Given this list of marker genes SMOC1, ALG2, FBXL3, TBR1, RUSC2, SOX4, IFT43, USP9X, COL1A2, KMT2A (NCBI Gene Id 79951), FAT4, ZMIZ1, PORCN, ZMYM2, GZF1, CTCF, B3GAT3, B4GALT7, ARFGEF2, SERPINF1, PKDCC, FERRY3, CHAT, FBXO11, MAP1B, SET (NCBI Gene Id 6418), TMCO1, MLXIPL, SHANK3, LRP5, PYCR2, PLK4, KDM3B, DLK1, POLR1A, CREBBP, EFNB1, ZNF341, TRIM8, SLC26A2, SEC24D, COL6A1, POGZ, DSE, EXOC6B, BBS1, WDPCP, BBS12, CHST14, TUBB3, MKKS, NSMF, ROR2, DNA2, LTBP4, STX1A, RAB3GAP2, CENPE, SLC39A13, SCAPER, GFPT1, HOXD13, KCNJ2, EP300, ALG14, ZFX, FOCAD, NPR3, ARL6, TAF1, MCTP2, GPC4, USB1, STAT4, ORC4, FMR1, IL1RAPL1, WASF1, TRAIP (NCBI Gene Id 10293), PAX2, COL6A3, RNF125, ABCC6, TBX1, SPARC, TTC8, SON, ATP6V1E1, KDM1A, FBLN5, PMM2, TGDS, TCTN3, ATRIP, STAC3, HNF1B, GJA8, KCNJ5, JMJD1C, SLC6A9, SIN3B, MAPK1, TACR3, COMT, PUS1, IL6ST, COL18A1, ARCN1, ORC6, B3GLCT (NCBI Gene Id 145173), NOTCH2, IL2RA, ADGRL1, ATN1, SLC10A7, SOS2, OTUD6B, RTL1, DPYSL5, FGF8, SLC25A1, JARID2, RASA2, SPART, CANT1, GMNN (NCBI Gene Id 51053), TNFRSF1A, RRAS, TBL2, FKBP6, SMAD2, SEMA5A, NPHP1, PROKR2, UFD1, PUF60, CSNK2A1, KMT2D, ELN, COL13A1, RAI1, HEPHL1, ANTXR1, YY1, HYMAI, LZTR1, DPF2, PPP1CB, CDT1, LONP1, RIN2, STAG1, SCARF2, PCNT, SIN3A, BBS7, ARVCF, UBE3A, SHOC2, UPF3B (NCBI Gene Id 65109), RECQL, DCPS, FGFR1, RAB3GAP1, KDELR2, LMNA, MBTPS2, SOBP, STRADA, EN1, RRAS2, NRAS, NEDD4L (NCBI Gene Id 93998), TRPS1, ECEL1, NUP85, MED12, ADAMTSL2, BAZ1B, PIGU, STAT3 (NCBI Gene Id 6774), PRDM5 (PR/SET domain 5), CRTAP, RIT1, HS6ST1, SPTAN1, CHAMP1, GP1BB, SNAP25, DDRGK1, PGM2L1, IFT122, GDF5, CCNQ, GLB1, SMARCE1 (SWI/SNF related, matrix associated, actin dependent regulator of chromatin, subfamily e, member 1), HNRNPK, PPP2R1A, SLC6A8, P4HTM, AP4S1, NSD1, COLEC11, SMARCA2, SYT1, ATP6AP1, MAP3K20, TAOK1, CRKL, GNE, RFX7, TRIM32, SPTBN1, ATP7B, KCNN3, CREB3L1, SMARCB1, TCF12, CCDC8, PAK2, SNUPN, ATP6V1B2, RMRP, NFIX, MRE11, NSUN2, BBS2, PIGT, TBL1XR1, DLG4, IFT74, MEG3, HNRNPH2, COL9A1, PIGP, AP1G1, TRIP11, NCF1, VPS13B, METTL27, TAC3, FKBP10, SLC35A2, LZTFL1, CDK10, GNB1, BBS4 (Bardet-Biedl syndrome 4), MKS1, ESAM, CHST3, H3-3B, COL9A3, DCHS1, PHF6, BBS10, NKAP, MTM1, EXT1, TMEM270, ARID1A, FGF17, RPS6KA3, ASPH, LMX1B, SLC35B2, SMS (spermine synthase), KDM6B, SDCCAG8, AP4M1, CTNND2, PLOD1, PYROXD1, SLC18A3, MICU1, GORAB, XYLT2, AEBP1, PTHLH, GATAD2B, YWHAG, MAN2B1, WNT1, KDM6A, OCRL, CD247, HYAL1, EIF4H, ZDHHC9, AGA, DNMT3A, ATP6V1A, IFT52, SCAF4, MARS1, BGN, DUSP6, BMP1, NANS, COL2A1, CUL4B, PHIP, SRCAP, SMARCA4, IPO8, TONSL, TELO2, MAP3K7, HNRNPH1, FARSB, KISS1, PLAGL1, TOGARAM1, CHD7, PCGF2 (polycomb group ring finger 2), MRAS, SATB1, RREB1, DHX30, RNF13, PPP1R15B, SPRED2, TGFB2, COL1A1, TANC2, CEP19, COL3A1, NEPRO, RYR1, HRAS, AP4E1, SYT2, MEFV, TMEM165, GAN, KAT6B, GNRHR, LIG4, IARS2, ARID1B, BBIP1, IFITM5, TRPV4, EED, SLC9A6, TAF4 (NCBI Gene Id 6874), PTCH1, CDK13, CHD3, RAD21, CSGALNACT1, CCDC47, SKI, ARF1, CEP152, ACAN, RBBP8, EHMT1 (NCBI Gene Id 79813), ALDH18A1, SEC24C, NHLH2, SETD1A, FBN1, NFASC, COL5A1, PIK3CA, THBS2, FILIP1, SOS1, AGRN, TNRC6B, COMP, ERMARD, AMMECR1, ZBTB20, BBS9, WDR35, VAMP1, SPRY4, ARID2, MYO9A, CEP290, PTEN, OBSL1, CUL7, DNAJC30, BUD23, POLR3GL, SLC2A10, PTPN11, RAF1, FGD1, NAE1, PIGS, TDO2, GALNS, SMAD3, GTPBP2, IL2RB, SATB2, EIF5A, MAMLD1, UBR1, H4C9, MAN1B1, TET3, SCLT1, THOC2, PRR12, MSTO1, CDC42BPB, SLC39A8, H4C5, OTX2, GRIA3, ACBD6, KCNH1, IFT56, BBS5, ANKRD55, TGFBR1, CAMTA1, RSPRY1, SOX9, APC2, PTDSS1, COL12A1, RAC1, TNXB, SMARCD1, PGM3, COL11A1, P3H1, TENT5A, PIK3R1, NPR2, DPAGT1, SUZ12, IFT172, HERC1, CDC6, VPS37A, CLIP2, VPS37D, GNB2, BCR, GNRH1, KRAS, GDF11, PIGG, LIMK1, EFEMP1, SP7, FKBP14, B3GALT6, SERPINH1, PUM1, NLRP1, NSDHL, C1S, EMILIN1, SLC5A7, TGFB3, PROK2, KISS1R, PDE4D, TRAF7, PLAA, PTPN22, WDR11, DNAJC21, RFC2, HDAC4, ZNF469, TLK2, RET, CEP104, EZH2, DPYD, ABL1, FLNA, CFAP418, NONO, NOTCH3, P4HB, RAP1GDS1, ATP6V0A2, POLR3A, AP4B1, RAP1B, GTF2I, EFEMP2, TMTC3, SOX11, COL6A2, IARS1, PPIB, WDR19, DDX3X, DEAF1, CBL, ANKRD17, CRELD1, ATP7A, KIF22, TRMT10A, FLNB, NGLY1, ADNP, BMP4, SEC23A, GTF2IRD2, C1R, COL9A2, IFT27, LTBP1, TNNC2, ZMYM3, PTPN2, YARS1, ENPP1, FARSA, CDC45, CAMK2A, BCL11A, ERI1, HIRA, BRAF, KANSL1, ORC1, TRIP4, NF1 (NCBI Gene Id 646021), TGFBR2, GTF2IRD1, BRPF1 (NCBI Gene Id 7862), COL5A2, MAP2K2, AHDC1, BICRA, PYCR1, GJA5, DDB1 (NCBI Gene Id 1642), ADAMTS2, PEX2, CTSK, SMARCC2, LMNB2, SCUBE3, ASAH1, DBH, H3-3A, FGFR3, LBR, XYLT1, LOX, ATR, GMPPB, here is a description of the gene set: Human Gene Set: HP_JOINT_HYPERMOBILITY Joint hypermobility The capability that a joint (or a group of joints) has to move, passively and/or actively, beyond normal limits along physiological axes. species: Homo sapiens